Given this list of marker genes PIK3CG, MAN2B1, EEF2, SERPINF2, BIRC3, TRAF4, DUSP5, LTA, NFKB2, HSP90AB1, JUND, LCP1, EIF1, GNAT2, IER2, PTK2B, JUNB (NCBI Gene Id 90482), RPS10, JUP, MYC (NCBI Gene Id 731404), EGR3, NPPB, TNF, ICAM1, EGR2, TNFAIP3, GADD45B, JUN, BTG2, BCL2A1, ZFP36, CD83, SEC24C (SEC24 homolog C, COPII coat complex component), SIAH2, CCL4, KLF6, IRF7, FTH1 (ferritin heavy chain 1), CCL3, RPS9, MCL1, EGR1, RPS16, HMGCS1, TNFSF9, INSIG1, KDM6B, TRAF1, DUSP2, NFKBIZ, ACKR3, HERPUD1, ACTB, CD69, ZC3H12A, GPR183, UBE2M, EEF1A1, NFKBIE, SLAMF1, NFKBIA, PPP1R15A, here is a description of the gene set: studied in species Homo sapiens from publication Dirmeier U, Hoffmann R, Kilger E, Schultheiss U, Briseño C, Gires O, Kieser A, Eick D, Sugden B, Hammerschmidt W (PMID 15674340) Latent membrane protein 1 (LMP1), an oncoprotein encoded by Epstein-Barr virus (EBV), is an integral membrane protein, which acts like a constitutively active receptor. LMP1 is critical for some facet of EBV's induction and maintenance of proliferation of infected B cells. It, in part, mimics signaling by the CD40 receptor and has been implicated in regulating proliferation, survival, or both properties of EBV-infected cells. We established a conditional LMP1 allele in the context of the intact EBV genome to define the immediate-early cellular target genes regulated by LMP1 in order to assess its contributions to infected human B cells. The functional analysis of this conditional system indicated that LMP1 specifically induces mitogenic B-cell activation through c-myc and Jun/AP1 family members and confirms its direct role in upregulating expression of multiple genes with opposing activities involved in cell survival. LMP1's signals were found to be essential for the G1/S transition in human B cells; cells lacking LMP1's signals are cell cycle arrested and survive quiescently. LMP1's activities are therefore not required to maintain survival in nonproliferating cells. LMP1 does induce both pro- and antiapoptotic genes whose balance seems to permit survival during LMP1's induction and maintenance of proliferation. Clusters 1 and 2: genes up-regulated in B2264-19/3 cells (primary B lymphocytes) within 30-60 min after activation of LMP1 (an oncogene encoded by Epstein-Barr virus, EBV). Human Gene Set: DIRMEIER_LMP1_RESPONSE_EARLY